Given this list of marker genes Slc12a2, Xpnpep1, Lars1 (leucyl-tRNA synthetase 1), Nup93, Ppp1r16b, Gosr1, Tmem161b (NCBI Gene Id 72745), Rnf139, Mup14, Cul5, Atg5, Ltbp1, Ap1ar, Nup58, Naa30, Spink5, Rp2, Phf20l1, Lipo2, Scamp1, Trp73, Snx7, Cacna1b, Fndc3b, Lipo3, Tollip, Ammecr1, G6pc1, Arl14ep, Rfx5, Dicer1, Myzap, Rrh, Nbeal1, Zbtb41, Ttc13, Cdkn2c, Emilin3, Cntn3, Ubqln2, Acer3, Zfand6 (NCBI Gene Id 80464), Cggbp1, Erbin, Nsmce2, Mup9, Zmynd11, Vopp1, Gjc3, Mup18, Fam163a, Mup1, Tnfaip8, Kdsr, Abca5, Apaf1, Phtf2, Mup7, Csnk1e, Cntn4, Anks1, Derl2, Kbtbd2, Arap3, Gpr158, Chst5, Mosmo (NCBI Gene Id 233812), Mup15, Prorsd1, Zfp523, Fam118a, Nkrf, Gria3, Chic1, Car10, Slain1, Mcf2l, Fam13c, Epha7, Stambpl1, Rap1b, Parg, Tent2, Mup8, Zmiz1, Tram1, Acsl4, Rc3h2, Mup2, Cmpk1, Mprip, Sptssa, Sestd1, Dpyd, Fyttd1, Rragd, Cox17, Misp3, Kdm7a, Snx4, Ntpcr, Stard4, Zfp709, Lrig2, Klhl29, Hnrnph1, Abca1, Arhgap29, Zim1, Has2, Bcl2l11, Herpud2, Bmpr2, Pcdh20, Zcchc2, Calhm2, Nhsl3 (NHS like 3), Flrt2, Or51ab3, Cry1 (cryptochrome circadian regulator 1), Taf5, Cks1b, Prex2, Trim2, Creld2, Scai, Cbx3, Fgb, Trps1, Ankib1, Hcn1, Fam241a, Rer1, Rpgrip1l, Mup10, Uqcrfs1, Ptbp3, Med1, Mnat1, Nckap1, Adam2, Mup19, Prok2, Nt5dc1, Zc3h12c, Fndc3a, Tmem39b, Fam120a, App, Fzd3, Acss3, Prl3a1, 2310022B05Rik, Cyp1b1, Cxadr, Mtdh, Mup12, Mup13, Bmpr1a, Ubqln1, Clock, Thg1l, Or51e2, Hnrnpm, Smad1, Hectd2, Wnk3, Cpeb2 (NCBI Gene Id 277866), Ebf3, Wdr26, Cacul1, Celf4, Nf1, Efhc2, Lnpep, Defb6, Ranbp3l, Pabir2, G3bp2, Rab21, Fsd1l, Pak3, Fam76b (family with sequence similarity 76, member B), Nop58, Mindy2, Prpf40a, Klhl2, Phactr3, Slc44a5, Agtr2 (NCBI Gene Id 11609), Tmem106b, E2f1, Fut8, Spdye4a, Pdhb, Cxxc4, Tead1, Snrpd3, here is a description of the gene set: from publication Chen Y, Wang X (PMID 31504780) Mouse Gene Set: MIR_291B_5P Genes predicted to be targets of miRBase v22 microRNA mmu_miR_291b_5p in miRDB v6.0 with MirTarget v4 prediction scores > 80 (high confidence targets). species: Mus musculus